Given this list of marker genes RYR2, ANK2, HCN3, HCN1, TBX18, HCN4, here is a description of the gene set: Any process that modulates the frequency, rate or extent of action potential creation, propagation or termination in an SA node cardiac myocyte. This typically occurs via modulation of the activity or expression of voltage-gated ion channels. species: Homo sapiens Human Gene Set: GOBP_REGULATION_OF_SA_NODE_CELL_ACTION_POTENTIAL